The following is a description of a gene set: species: Homo sapiens Human Gene Set: GOBP_MITOCHONDRIAL_RNA_CATABOLIC_PROCESS The chemical reactions and pathways resulting in the breakdown of RNA transcribed from the mitochondrial genome and occurring in the mitochondrion., and this is the list of marker genes: PDE12, C1QBP, SLIRP, NSUN4, SUPV3L1 (Suv3 like RNA helicase), PNPT1, LRPPRC, GRSF1